Given this list of marker genes ALG5, SLC40A1, FAM117B, LPAR6, EMB, TNFAIP8L2, HESX1, D2HGDH (D-2-hydroxyglutarate dehydrogenase), PTS, TRO, PPOX, NDRG1, STK24, ACAT2, PTPRF, SDHAF2, NF2, RGS2, SLC25A45, MEF2D, HACD1, ZFP36L2, KLF4, CALHM2, RASA3, ZNF202, SCARB1, GSTM4, CLTC, YWHAB, FGD4, IFT81, SYDE1, HNRNPL, ZFP90, OLFM1, BAMBI, PID1, VAMP1, ANGPTL4 (angiopoietin like 4), COL4A2, C15orf39, CNR2, DECR2, PRSS22 (serine protease 22), LPCAT4, GCNT1, RPA1, RNASEL, ZNF414, ASTN2, DAP, IRF4, UGP2, C2orf69, RAP2A, HSD17B6, SNX30, POLK, ALDH3B1, PHF23, SAMD1, LOXL3, RHOV, PDCD4, GPD1L, USP22, LPXN, COMT, ARHGAP19, VANGL1, SMIM19, RNF144B, DMD, SIKE1, SOCS6, FAM217B, OTUD1, KPNB1, OSBPL11, KCNE3, THBD, FAM234B, DYDC2, MBNL1 (NCBI Gene Id 9850), CRHBP, USP48, IRF2BPL, ZNF703, EPS8, CDK20 (cyclin dependent kinase 20), DNA2, CASP2, NGFR, DAB2, TMEM80, ZNF710, SPRR3, RND3, ANGPTL2, HMOX2, TNKS2, SNX33, CHST14, IDH1 (isocitrate dehydrogenase (NADP(+)) 1), PXN, RNF44, TIFAB, LRP1, CBFB, CPA2, FBXO21, RFK, KLF2, GOLM1, KBTBD11, PAQR4, AAGAB (alpha and gamma adaptin binding protein), DBP, RPL39L, MNT, TAB1, METTL17, NEDD9, TNFRSF13B, DNAH7, ALOX5AP, SLC35E3, HHEX, SLC36A1, AP2S1, FCER1G, ARHGAP9, CD209, ABI3, TRMT61A, FOXA3, DDX31, NFATC2, TAL2, HPGD, INPP5D (inositol polyphosphate-5-phosphatase D), ZRANB3, CD180, ETV5, CEBPA, MGAT1, KCNJ3, SEPTIN9, SLC25A22, SLC47A1, HES6, HTR1F, DENND10, ST8SIA4, FAM117A, TMEM86A, CLNS1A, EMC3, UGT2A3, C9orf85, ZSWIM1, ARHGEF18, NHLRC1, USF1, SLC66A2, GPR160, DMWD, CTSA, ARSB (arylsulfatase B), EIF2AK1, TCTA, TNS4, USP8, FRAT2, PNP, RETREG3, CNIH1, MAFB, NT5M, FGFR1, TENT5A, NEIL1, ARRDC3, ZDHHC8, KLF9, MTSS1, PRR14L, MED25, TLK1, MFAP3, PAQR7, CERK, DGKZ, ZNF157, ARHGAP25, SH2D3C, MAPK12, PDP1, AMZ1, here is a description of the gene set: Human Gene Set: GSE26343_WT_VS_NFAT5_KO_MACROPHAGE_LPS_STIM_UP from publication Buxadé M, Lunazzi G, Minguillón J, Iborra S, Berga-Bolaños R, Del Val M, Aramburu J, López-Rodríguez C (PMID 22312110) Gene expression from WT and NFAT5 KO primary macrophage cultures. species: Homo sapiens Genes up-regulated in bone marrow-derived macrophages stimulated with LPS: wildtype versus NFAT5 knockout.